Given this list of marker genes Bgn, Hapln1, Amelx, Lum, Ogn (NCBI Gene Id 73237), Spock2, Dcn, Enam, Aspn, Ambn, Hspg2, Prelp, Prg2, Vcan, here is a description of the gene set: Mouse Gene Set: GOMF_EXTRACELLULAR_MATRIX_STRUCTURAL_CONSTITUENT_CONFERRING_COMPRESSION_RESISTANCE studied in species Mus musculus A constituent of the extracellular matrix that enables the matrix to resist compressive forces; often a proteoglycan.